The following is a description of a gene set: The process in which the 3' end of a pre-tRNA molecule is converted to that of a mature tRNA. Mouse Gene Set: GOBP_TRNA_3_END_PROCESSING studied in species Mus musculus, and this is the list of marker genes: Trnt1, Ssb, Elac1 (elaC ribonuclease Z 1), Trmt10c, Ptcd1, Elac2, Hsd17b10